The following is a description of a gene set: from publication Chen Y, Wang X (PMID 31504780) studied in species Mus musculus Genes predicted to be targets of miRBase v22 microRNA mmu_miR_7656_3p in miRDB v6.0 with MirTarget v4 prediction scores > 80 (high confidence targets). Mouse Gene Set: MIR_7656_3P, and this is the list of marker genes: Eloa, Lrrc10b, Plekhf1, Tnfaip1 (tumor necrosis factor, alpha-induced protein 1 (endothelial)), Tead1, Arf4, Snph, Dnaja2, Uba1y, Disp3, Mprip, Adpgk, Aak1, Scn1a, Ppm1h, Ociad1, Fbxo11, Nol6, Vsig10, N4bp1, Xlr5a, Arf1, Tbc1d24, Ip6k2, Irf1, Pfkfb2, Slc35e1, Rrad, Gabpa, Emc3, Snta1, Plac8, Rgn, Eif3j2, Mau2 (MAU2 sister chromatid cohesion factor), Ppp1r9b, Efcc1, Chst3, Col23a1, Slain2, Tysnd1, Lrrfip2, Ubqln2, Zmiz1, Kcnma1, Nek1, Grem1, Map3k3, Lpo, Eif3j1, Adcyap1r1, Faap20, Zkscan8, Fam168a, Ubac2, Irgq, Als2cl, Snx17, Rgs2, Prpf3, Kpna3, Efna5, Hdlbp, Ptpre, Agap1, Sec22a, Aptx, Nat8l, Plekho2, Armc5, Traf4, Sorcs3, Lrtm2, Hunk, Tmem214 (NCBI Gene Id 97201), Ints10, Ccr7, Ano6, Kremen1, Cln6, Atp1b2, Kif1a, Glyr1, Serpinb9, Adra2b, Tbc1d8b (NCBI Gene Id 75757), Nfix, Scn2a, Serpinb9b (NCBI Gene Id 72011), Abhd3, Csf2rb, Atp6v0c, Ccdc88a, Mmp15, Gpalpp1, Synpo2 (NCBI Gene Id 99735), Cyct, Slc4a4